Given this list of marker genes S100A11, ANXA3, SPI1, CAP1, MKRN1, RAB5IF, CD302, ERP44, LYL1, MAP2K4, CAPZA1, TNP1, RBCK1, TM6SF1, STAT1, BID, DAZAP2, EXT1, CDC42EP2, GK, PELI1, FPR2, GNG5, ASPH, XKR8, PELO, RAF1, CEACAM5, MTMR3, SGK1 (serum/glucocorticoid regulated kinase 1), LHX6, UBE2D3, ICAM3, HLA-C, PFKFB3, TSG101, SRPK2, LYN, ADGRG3, DENND5A, VDR, ACP3, CHD7, TBX3, AGO4 (NCBI Gene Id 54791), ADGRE2, PLSCR1 (phospholipid scramblase 1), MXD1, PLXNC1, KDM5A, SMIM27, SDF2, TAOK3, AIF1, PLA2G5, C5AR1, CAMK1D, RNF24, SCO2, ZNF394, SLPI (secretory leukocyte peptidase inhibitor), ATP6V1B2, IFNAR2, AATK, ACSL1, IVNS1ABP, APOBEC3A, GK3, NFIC, FBXL5, SLCO3A1, SH3GLB1, KYAT3, SGTA, LIMK2, AMPD3, ACTR3, BACH1, SERINC3 (NCBI Gene Id 10955), DENND3, UBE2J1, GLRX, REL, OXT, MYO5A, MIR22HG, PRKD2, TM9SF2, SLC12A6, SNIP1, YIPF6, PISD, BTG1, CNTNAP3B, NLRP3, POFUT2, ARL4A, FAM131A, LILRA1, FCAR, GIT2, SLC31A2, B4GALT5, MARCKS, NCOA1, RGL2, ANPEP, PINK1, GOLGA2, KLF7, SECTM1, ADGRE5, CD9, S100P, DNAJB9, B9D2, FOSL1, IL1RN, LRP10, CCR1, IMPA2, GNAQ, MOSPD2, VCPIP1, SNORA21, PPP6C, GBP2, DGLUCY, H3C2, SDCBP, ADIPOR1, SLC22A18, YIPF1, SORL1, PNPLA3, NDUFB3, VNN3P, BRD4, SLA, MSRA, ANKRD55, CHSY1, VPS37B, KLF2, ALOX5, HLX, NCOA4, DHX34, NEDD9, TYK2, FCGR1A, SLC25A44, ADAM10, SLC6A6, LPAR2, RIGI, BLTP3B, ADAP1, CFLAR, PPP4R1, TAB2, VPS37C, UPF1 (NCBI Gene Id 5976), EPS15L1, PLIN3, CKAP4, CYTIP, FYB1, H2BC4, ZFP36L1, ADAM8, TNNI2, PCIF1, RAB20, RNF141, NDUFB6, IRF9, PSAP, BTK, HOXA11, ZNF674 (NCBI Gene Id 641339), FOXN3, TRIM25, CFD, MMP9, OGFRL1, MFAP3L (NCBI Gene Id 9848), WDR26, RARA, SEC14L1, ATP11A, ARPC5, PCDH12, IGFBP2, SLC22A4, IQSEC1, IFIT2, OR3A1, DBN1, here is a description of the gene set: from publication Jeffrey KL, Brummer T, Rolph MS, Liu SM, Callejas NA, Grumont RJ, Gillieron C, Mackay F, Grey S, Camps M, Rommel C, Gerondakis SD, Mackay CR (PMID 16474395) Human Gene Set: GSE3982_NEUTROPHIL_VS_NKCELL_UP Genes up-regulated in comparison of neutrophils versus NK cells. studied in species Homo sapiens In the present study we used Affymetrix oligonucleotide microarrays to produce gene transcription profiles for the major leukocyte types in humans. This comprehensive dataset enabled us to not only establish which genes were expressed in each leukocyte type, but also which genes were expressed in each subset after activation. The used of a comprehensive dataset of gene profiles from all the major human leukocyte subsets enabled a novel and powerful means for identification of genes associated with single leukocyte subsets, or different immune paradigms.